The following is a description of a gene set: IFNG signaling activates MAPKs Human Gene Set: REACTOME_IFNG_SIGNALING_ACTIVATES_MAPKS species: Homo sapiens, and this is the list of marker genes: MAPK3, IFNGR1, IFNGR2, MAPK1, IFNG (interferon gamma), RAF1, JAK1, JAK2